The following is a description of a gene set: Prolonged partial thromboplastin time studied in species Homo sapiens Increased time to coagulation in the partial thromboplastin time (PTT) test, a measure of the intrinsic and common coagulation pathways. Phospholipid, and activator, and calcium are mixed into an anticoagulated plasma sample, and the time is measured until a thrombus forms. Human Gene Set: HP_PROLONGED_PARTIAL_THROMBOPLASTIN_TIME, and this is the list of marker genes: F11, B4GALT1 (NCBI Gene Id 2683), VPS33B, LMAN1, PGM1, F10, MPV17, SLC37A4, F9, F12, OTC, GGCX, KLKB1, ALG2, AKR1D1, SOS1, HLA-DQA1, ALG13, FAH, GNE, DPM1, KNG1, ABCD3, AMACR, PMM2, PLOD3, MCFD2, GATA6, ALG12, LRPPRC, EFL1, F2, HLA-DQB1, F5, F8, LZTR1